Given this list of marker genes CCN3 (cellular communication network factor 3), RASL12, HSPB1, MYH11, GJA1 (NCBI Gene Id 7953), MYLK, KCNMB1, PRELP, EMP2, EID1 (NCBI Gene Id 27110), DSEL, ID4, PFKM, SYNPO2, GRK5, CPED1, PMEPA1, NIBAN1, MAP1B, ACTC1, SOD3, DSTN, EGFR, PTGIS, FMOD, JAM3, TNS1, TPD52L1, LHFPL6, SORBS2, CRIM1, FIBIN, SUSD5, MAGED2, RABGAP1, ADCY9, PKIG, MXRA7, PAM, LMOD1, PKD2, MYLIP, CSRP2, here is a description of the gene set: species: Homo sapiens Genes down-regulated in unstable ateroslerotic plaques compared to the stable ones. from publication Papaspyridonos M, Smith A, Burnand KG, Taylor P, Padayachee S, Suckling KE, James CH, Greaves DR, Patel L (PMID 16741146) Human Gene Set: PAPASPYRIDONOS_UNSTABLE_ATEROSCLEROTIC_PLAQUE_DN OBJECTIVE: Comparison of gene expression in stable versus unstable atherosclerotic plaque may be confounded by interpatient variability. The aim of this study was to identify differences in gene expression between stable and unstable segments of plaque obtained from the same patient. METHODS AND RESULTS: Human carotid endarterectomy specimens were segmented and macroscopically classified using a morphological classification system. Two analytical methods, an intraplaque and an interplaque analysis, revealed 170 and 1916 differentially expressed genes, respectively using Affymetrix gene chip analysis. A total of genes were identified from both analyses. The differential expression of genes was also confirmed using quantitative-polymerase chain reaction on a larger panel of samples. Eighteen of these genes have not been associated previously with plaque instability, including the metalloproteinase, ADAMDEC1 (approximately 37-fold), retinoic acid receptor responder-1 (approximately 5-fold), and cysteine protease legumain (approximately 3-fold). Matrix metalloproteinase-9 (MMP-9), cathepsin B, and a novel gene, legumain, a potential activator of MMPs and cathepsins, were also confirmed at the protein level. CONCLUSIONS: The differential expression of genes not previously associated with plaque rupture has been confirmed in stable and unstable regions of the same atherosclerotic plaque. These genes may represent novel targets for the treatment of unstable plaque or useful diagnostic markers of plaque instability.